The following is a description of a gene set: Human Gene Set: GOBP_ENDOCARDIUM_DEVELOPMENT The process whose specific outcome is the progression of the endocardium over time, from its formation to the mature structure. The endocardium is an anatomical structure comprised of an endothelium and an extracellular matrix that forms the innermost layer of tissue of the heart, and lines the heart chambers. species: Homo sapiens, and this is the list of marker genes: SOX18, NOTCH1, ACVR1, OVOL2, RBPJ, KDR, STK4 (serine/threonine kinase 4), SMAD4, NRG1, STK3, PROX1, SOX17